Given this list of marker genes Dnajb14, Pcmtd2, Pdlim5 (PDZ and LIM domain 5), Plxna4, Slc35d3, Pcdha6, Atp5mc3 (ATP synthase membrane subunit c locus 3), Esrrb, Rnf44, Myc, Fnbp1, Pcdha11, 1700129C05Rik, Leng8, Pcdha9, Nr3c1, Gtf3c5 (general transcription factor IIIC, polypeptide 5), Pcdha12, G6pc2, Vamp3, Pcdha5, Fastkd3, Zfp322a, Hpn, Gabra2, Ube2a, Slbp, Pcdha1, Arl14, Pcdha3, Exo5, Elf2, Ankrd49 (NCBI Gene Id 97557), Pcdha8, Ssbp3, Mysm1, Stk17b, Pcdha4, Rgmb, Cse1l, Pcdhac2, Wdr38, Mlx, Slc35a3, Il2rg, Pcdha2, Smarcd1, Pcdha10, Ablim1, Atf7ip2, Usp21, Zeb1, Cep350, Tmeff2, Gng12, Ywhaz, Rbm41, Pcdhac1, Atp8b1, Pcdha7, Fbxo8, here is a description of the gene set: Genes predicted to be targets of miRBase v22 microRNA mmu_miR_6408 in miRDB v6.0 with MirTarget v4 prediction scores > 80 (high confidence targets). Mouse Gene Set: MIR_6408 species: Mus musculus from publication Chen Y, Wang X (PMID 31504780)